The following is a description of a gene set: species: Mus musculus Any process that regulates the concentration of calcium in the postsynaptic cytosol. Mouse Gene Set: GOBP_REGULATION_OF_POSTSYNAPTIC_CYTOSOLIC_CALCIUM_ION_CONCENTRATION, and this is the list of marker genes: Myo5a, Wnt5a, Fzd9, Grin2b, Grm1, Grid2ip, Itpr1, Synpo, Calb1